The following is a description of a gene set: species: Mus musculus Mouse Gene Set: GOBP_RETICULOPHAGY The selective autohagy process in which parts of the endoplasmic reticulum are loaded into autophagosomes, delivered to the vacuole, and degraded in response to changing cellular conditions., and this is the list of marker genes: Tex264, Ufl1, Retreg2, Atg9b, Rb1cc1, Atg9a, Atg2b, Sting1, Retreg3, Ddrgk1, Bnip3, Ulk1, Atg2a, Snx7, Uba5, Ulk2 (NCBI Gene Id 320511), Ufm1, Cdk5rap3, Snx30, Ufc1, Retreg1, Ulk3